The following is a description of a gene set: Human Gene Set: HP_ABNORMAL_VAS_DEFERENS_MORPHOLOGY Abnormal vas deferens morphology A structural anomaly of the secretory duct of the testicle that carries spermatozoa from the epididymis to the prostatic urethra where it terminates to form ejaculatory duct. studied in species Homo sapiens, and this is the list of marker genes: HFE, KCNN4, ADGRG2, EDNRA, SLC11A1, GSTM3 (NCBI Gene Id 2947), HMOX1, MIF, CEACAM3, GCLC, HNF1B, TGFB1, SERPINA1, SLC9A3, SLC26A9, CEACAM6, AR, DCTN4, SLC6A14, CLCA4, CFTR, STX1A